Given this list of marker genes Mtmr2, Synj1, Mtmr4, Pten, Mtmr7, Mtmr12, Mtm1, Sacm1l, Mtmr1, Mtmr6, Fig4, Mtmr10, Mtmr11, Mtmr14, Mtmr3, Inpp5f, Synj2, here is a description of the gene set: studied in species Mus musculus Mouse Gene Set: GOMF_PHOSPHATIDYLINOSITOL_MONOPHOSPHATE_PHOSPHATASE_ACTIVITY Catalysis of the reaction: phosphatidyl-1D-myo-inositol monophosphate + H2O = phosphatidylinositol + phosphate.